The following is a description of a gene set: from publication Chen Y, Wang X (PMID 31504780) Genes predicted to be targets of miRBase v22 microRNA hsa-miR-1229-5p in miRDB v6.0 with MirTarget v4 prediction scores > 80 (high confidence targets). species: Homo sapiens Human Gene Set: MIR1229_5P, and this is the list of marker genes: TAL1, GPD1, ZC3H13, NUP93, PKD2, FLOT1, WIPF1, TESPA1, BDP1 (NCBI Gene Id 59278), TRPC6, ICAM5, ZNF124, YAE1, GRIK1, TMEM212, BCL6, ADAR, PLVAP, WLS, ARHGEF28, RPS6KA5, RBMXL3, MEIOC, MITF, IQGAP3, ZXDB, CSNK2A1, CHGB, PNMA8A, RBMXL1, EPHA5, TBC1D7, CA10, PDE7B, RBMX, MTUS2